Given this list of marker genes Dcaf12, Gdi2, Bcl11a, Ubb, Dpysl2, Clec9a, Scd2 (stearoyl-Coenzyme A desaturase 2), Git2, Bin3, Tmem50a, Ccdc28b, Kctd14, Rbfa, Rbmxl1, Anxa6, Psmb8, Abca3, Cd180, Lmo1, Notch2, Mrpl28, Pld4, Hepacam2, Ppt1, Unc119b (unc-119 lipid binding chaperone B), Hspe1, Laptm5, Alcam, Cyb5r1, Unc119, Ly86, Fgd2, St3gal5, Acaa1a, Srsf11, Jund, Dipk1a, Naaa, Tgfbi, Sptbn1, Etfb, Rnd3, Ms4a6c, Rtraf, Fzd1, Evl, Taldo1, Glud1, Uqcc2, P3h2, Gnb2, Nr4a1, Pstpip1, Tceal9, Hk2, Snhg6, Dctpp1, Ndufa8, Fam50a, Arhgap9, Mapk14, P2ry6, Acss1, Fkbp3, Plekha5, Fxyd5, Celf2, Anxa1, Zfp282, Ppfibp2, Myo1f, Srebf2, Atp5if1, Pycard, Sptssa, Ctdp1, H2-Oa, Il16, Rgs18, Mfsd14a, Susd3, Sigmar1, Sema4d (NCBI Gene Id 20354), Grcc10, Naga, Macroh2a1, S100a10, Xcr1, Akr7a5, Btg2, Tmsb10, Fam149a, Snx5, Havcr2, Pdlim2, Mbnl1, Alox5ap, Atg3, AB124611, Olfm1, Tlr12, Rex1bd, Ptma, Txndc16, H2-Ob, Cd24a, Hexb, Lbh, Gsn, Hltf, Hspa1b, Irag2, Cxcr3, Ndufb10, Plekhm3, Uba52, Parp1, Npm1, Dctn5, Itga1, H2-DMb1, Psap, Sf3b5, Tnfaip8l2, Lmo4, Glrx, Ucp2, Rgs10, Cd48, Cenpv, Stap1, H2az2, Slc31a2 (solute carrier family 31, member 2), Ccdc12, Ppp1ca, Tmco1, Tifa, Hspa8, Ciita, Cd68, Cbl, Ppfia4, Ckb, Arpc2, Slc66a2, Creg1, Mrpl18, Nfatc2, Lyz2, Txnip, Twf2, Marchf1, Was, Dbn1, Rnase6, Hint1, Nsmaf, Amz1 (NCBI Gene Id 231842), Mctp1, Arhgef6, Septin3, Hmgb2, Dbnl, Ndufc2, Parp8, Nr4a2, Erp29, Arhgdib (Rho, GDP dissociation inhibitor beta), Cyp27a1, Zfp36l2, Klf2, Iqgap2, Zfp385a, Plbd1, Plcb2, Irf8, Plac8, Gna15, Ptms, Mvb12a, Rbbp7, Fos, Plcb4, Mef2c, Dna2, Tlr3, Rab32, Ramp1, Itgb2, Cmtm7, Ptpn6, Cnih4, Csk, Coro1a, Tyrobp, Bnip3l, Asb2 (ankyrin repeat and SOCS box-containing 2), Naca, Ahsa1, Otulinl, Fam111a, Btk, Cd36, H13, Gpx1, Rtl8b, Strbp, Tm2d2, Itm2b, Klf4, Crip1, Lpxn, Arhgap18, Tm6sf1, Lipa, Pianp, Egr1, Ccnd1, Cyth4, Serpinf1, Lamtor4, Atp5mc2, Rab11a, Slc35c2, Ptpre, Tex261, Cdk4, Inpp5d, Slk, Rtl8a (retrotransposon Gag like 8A), Selenoh, Asah1, Pdcd2l (programmed cell death 2-like), Rgs2, Pitpna, Pip4p1, Unc93b1, Hps3, Ppp3ca, Rtcb, Septin6, Dpy19l1, Mpeg1, Mlec, Commd8, Dhrs1, Snx3, Leprotl1, Snrpd2, Eif3e, Rab7b, Mcm6, Zfp706 (zinc finger protein 706), Uqcrb, Bola1 (bolA family member 1), Tln1, Pals2, Siva1, Plp2, Arsb, Cbx3, Idh2, Atf3, Snrpe, Polr2g, Txn2, Gm2a, Lrrc25, Slc9a9, Lage3 (NCBI Gene Id 66192), Rasgrp4, Vrk1 (vaccinia related kinase 1), Tmed3, Fcgr2b, Zyx (NCBI Gene Id 97340), Hsp90ab1, Mdh1, Itgb7, Itpr1, Ighm, Cyb5a, Cd37, Evi2a, Mxd4 (NCBI Gene Id 69247), Rraga, Samd9l, Cited2, Ifngr1, Lamtor1, Jun, Myl12b, Rac2, Chchd1, Lpar6, Eno1, Nsa2, Lrrk2, Lamtor2 (late endosomal/lysosomal adaptor, MAPK and MTOR activator 2), Hells (NCBI Gene Id 77871), Ccr2 (C-C motif chemokine receptor 2), Anp32a, Treml4, Rhob, Zfp710, Fosb, Plin2, Gltp, Polr1a, Agpat3, Ap1s3, Abhd17a, Dut, Naa10, Hexa, Itpripl1, Trf, Kctd12, Psmb9, Ctnnbip1, Arhgap45, BC028528, Srgap3, Atp5f1c, Ldha, Pid1, Acaa2, Dnaja1, Acox3, Septin9, Cd300c2, Tifab, Pold4 (polymerase (DNA-directed), delta 4), Tkt, H2-DMa, Rnf130, Arhgap5, Anp32b, Calm1, Ndufa6, Impa2, Ehd4, Gnai2, Cat, Sdf2l1, Mrpl52, Sumo3, Grap2, Ptpn18, Scp2 (sterol carrier protein 2, liver), Cotl1, Pafah1b3, Camk1d, Ubash3b, Rbpj, Glrx5, Gpr34, Man2b1, Reep5, Banf1, Clic1 (NCBI Gene Id 114584), Nap1l1, Bmyc, Pak1, Trim12c, Pik3cb, Lat2 (NCBI Gene Id 65021), Hspa1a, Cnp, Gpr65, Dnajc7, Slc25a5, Coro7, Ppm1m, here is a description of the gene set: Cytokines mediate cell-cell communication in the immune system and represent important therapeutic targets. A myriad of studies have highlighted their central role in immune function, yet we lack a global view of the cellular responses of each immune cell type to each cytokine. To address this gap, the authors created the Immune Dictionary, a compendium of single-cell transcriptomic profiles of more than 17 immune cell types in response to each of 86 cytokines (>1,400 cytokine-cell type combinations) in mouse lymph nodes in vivo. A cytokine-centric view of the dictionary revealed that most cytokines induce highly cell-type-specific responses. For example, the inflammatory cytokine interleukin-1β induces distinct gene programmes in almost every cell type. A cell-type-centric view of the dictionary identified more than 66 cytokine-driven cellular polarization states across immune cell types, including previously uncharacterized states such as an interleukin-18-induced polyfunctional natural killer cell state. studied in species Mus musculus Genes negatively differentially expressed in cell type: cDC1 (conventional dendritic cell type 1) upon treatment with cytokine: TNF-α in mouse lymph nodes in vivo. Mouse Gene Set: CUI_CDC1_TNFA_RESPONSE_DN from publication Cui A, Huang T, Li S, Ma A, Pérez JL, Sander C, Keskin DB, Wu CJ, Fraenkel E, Hacohen N (PMID 38057668)